The following is a description of a gene set: RNA polymerase II transcribes snRNA genes Human Gene Set: REACTOME_RNA_POLYMERASE_II_TRANSCRIBES_SNRNA_GENES studied in species Homo sapiens, and this is the list of marker genes: GTF2E2, INTS3, GTF2A1, INTS2 (NCBI Gene Id 86656), POLR2L, RNU1-1, TAF8, POLR2G, RPAP2, SSU72 (SSU72 homolog, RNA polymerase II CTD phosphatase), RNU2-1, ELL2, POLR2F, INTS13, SNAPC1, ELL3, SNAPC3, POLR2I, POLR2B, POLR2C, RPRD2, CDK9 (cyclin dependent kinase 9), POLR2J, INTS11, SRRT, CCNK, SNAPC2, RNU4-1, INTS8, RNU4ATAC, ICE1, INTS5, INTS6, INTS10, RNU12, NCBP2, GTF2B, POU2F2, INTS12, RPRD1A, NABP2, POLR2D, TAF9, POU2F1, RNU11, TAF11, PCF11, NCBP1, GTF2F1, TAF6, INTS7, INTS4, TAF13, SUPT5H, RNU5A-1, PHAX, GTF2F2, INTS9, CCNT1, POLR2H, NABP1, TAF5, RPRD1B, POLR2A, GTF2A2, SUPT4H1 (SPT4 homolog, DSIF elongation factor subunit), SNAPC4, ZNF143, INTS14, CDK7, POLR2E, POLR2K, SNAPC5, ZC3H8, ELL, INTS1, GTF2E1, TBP, ICE2, CCNT2, SP1